The following is a description of a gene set: Abnormal circulating ornithine concentration Human Gene Set: HP_ABNORMAL_CIRCULATING_ORNITHINE_CONCENTRATION species: Homo sapiens Deviation from the normal concentration of ornithine in the blood circulation., and this is the list of marker genes: OAT (ornithine aminotransferase), AASS, ALDH18A1, SLC25A15, CA5A